Given this list of marker genes APEX1, KLHL32, MAGEA5P, LRRC8A, PM20D1, PML, TAF4B, HSPA5, KAT14, DSC2, KMT2A, BCCIP, PIGZ, RPS6KA3, COL8A2, BTBD1, MTSS1, GAB3, SELENOH, RUNX2, UBE2D3, CMTM6, ENSG00000266560, ADRA1A, PTPRM, PLD1, PAFAH1B1, TOP2A, FAM120C, NID1, SKI, ESYT1, NXF3, MTCL2, COG7, KIFC1 (kinesin family member C1), CCDC6, PRX, SIDT2, MPPE1, METTL8, IFNAR1, GLUL, SLC11A2, CCL20, PLXDC2, RIT2, HACD3 (NCBI Gene Id 95112), CD69, NAA15, here is a description of the gene set: from publication Chen Y, Wang X (PMID 31504780) studied in species Homo sapiens Human Gene Set: MIR635 Genes predicted to be targets of miRBase v22 microRNA hsa-miR-635 in miRDB v6.0 with MirTarget v4 prediction scores > 80 (high confidence targets).